Given this list of marker genes RECQL, SLC25A46, RBX1, DNAJC5, SMC3, KYAT3, PMS2, KDM5C, RAB13, AKR1B1, ZNF329, BDH1, CBX3, COX19, DBR1, ELF2, COA5, PLP1, POLD2, NAPG, NOP16, LTO1, PARL, LYL1, RAB14, C1orf43, GLTP, ENPP1, SLFN12, SMC6, EXOC8 (exocyst complex component 8), PSMB9, TMEM223, PPP2R5C, ZMAT3, ZFAND2A, HPS3, NCAPH2, ARMC7 (armadillo repeat containing 7), UNC50, DAZAP2, SPRY4, TBC1D17, NUDCD2, SERF2, TOPORS (TOP1 binding arginine/serine rich protein, E3 ubiquitin ligase), CBLN3, RRP1B, CRYBA4, DDX49, VCF1, LUC7L2, ZMYM5, OAS2, MCM7, YJEFN3, MRPS15, CAPN6, RNF114, FKBPL, VKORC1, BIRC2, EED, MAU2, MRPL50, TSC22D3, LIPT2, HNRNPUL1, PHF23, NELFB, EIF5, ELOVL1, GPX1, SYPL1, ANGEL2, METTL6, TOR4A, CNN2, SENP1, SNIP1, RAD54L, NUDT16L1, CORO1A, ALDH9A1, ZNF823, RPS15A, PABPN1, TCIRG1, FAM120A, PPIL4, NDUFA3, CASP1, ARFGAP1, CDC37L1, XBP1, SLC25A4, HCFC1R1, MAGI2, RPS11, TMEM140, ZCCHC3, UBP1, SREK1, ZNF841, ATP5IF1 (NCBI Gene Id 93974), KCNMB1, CBLL1, PTPN18, THUMPD1, PLEKHG5, TTF1, TMOD3, RBM10, PPM1G, MEA1, HLTF, DHX36, SMIM14, DUSP12, SEH1L, FAM89B, MRPL51, MGAT2, EIF1AX, RFC1, LPGAT1 (lysophosphatidylglycerol acyltransferase 1), FKBP7, BRDT, TTK, NOPCHAP1, GTF2H1, RNF32, KLHDC3, NXT1, DBNDD2, GYG1, VPS9D1, RPL12, SNAPC2, GDF10, ZNF688 (NCBI Gene Id 146542), CPTP, LUC7L, FUBP1, DNAJC18, CALCOCO2, SHARPIN, CCN4, ARL5A, COMMD6, A4GALT, MFAP1, BTF3L4, CXXC1, MIA3, PRR15, DPH7, MOS, PARP3 (poly(ADP-ribose) polymerase family member 3), TSR3, SMC4, RBM5, ARGLU1, TRPV6, EID1, LSM3, MIDN, SLC25A45, HSPA2, KLHL9, CHCHD1, DYNLRB1, DUT, SUDS3, TECPR1, EIF4H, ARMC10, ZDHHC4, HCLS1, ZNF274, SARNP, PSEN1, ZFP1, PGP, FIZ1, MED17, BPNT1, GADD45G, ELOF1, RHOQ, EPS15, INO80E, SLC14A1, CBFB, ZNF808, DCXR, EIF1B, PDPK1, YTHDF2, here is a description of the gene set: Human Gene Set: GSE17721_POLYIC_VS_PAM3CSK4_1H_BMDC_UP mouse primary BMDCs were stimulated with tlr ligands and gene expression changes were profiled on Affymetrix arrays Genes up-regulated in comparison of dendritic cells (DC) stimulated with poly(I:C) (TLR3 agonist) at 1 h versus DC cells stimulated with Pam3Csk4 (TLR1/2 agonist) at 1 h. studied in species Homo sapiens from publication Amit I, Garber M, Chevrier N, Leite AP, Donner Y, Eisenhaure T, Guttman M, Grenier JK, Li W, Zuk O, Schubert LA, Birditt B, Shay T, Goren A, Zhang X, Smith Z, Deering R, McDonald RC, Cabili M, Bernstein BE, Rinn JL, Meissner A, Root DE, Hacohen N, Regev A (PMID 19729616)